Given this list of marker genes Trappc3, Med1, Lhx2, Psph, Rpl27, Zfp882, Spmip8, Gart, Slc6a16, Aamp, Tbc1d8, Apoa1, Acaca, 4933434E20Rik, Hnrnph3, Sgcd, Hsd11b2, Peg12, Sirt1, Elk3, Enoph1, Tmem45a, Purb, Tmem64, Dcp1b, Meis3, 4930505N22Rik, Cobll1, Aven, Uvrag, Mir8102, Nudt6, Sema3a, Trp53inp1 (transformation related protein 53 inducible nuclear protein 1), Plcb4, Idi1, Cdc42ep1, Moap1, Mrm1, Gnpat, Sugct, Msrb1, Cyp39a1, Art3, Lsm1, Zmynd11, Smc2, Csnk1e, Zfp740, Il17ra, Vps13a, Pigo, Gm10517, Gm32950, Gm13375, Zfp11, 4930439D14Rik, Ina, Fhdc1, Arhgap22, Morrbid, Tyro3, Gm27521, Psmb7, Ccdc160, Wnk2, Gm13503, N4bp3, P2ry6, Usp19, Parp9, Zfp703, Baiap2l2, Lin37 (lin-37 DREAM MuvB core complex component), Atxn1l, Naa12, Klc2, B230322F03Rik, Lzts1, Arl1, Fkbp6, Nuak1, Ftx, Ush1g, Agtrap, Adad2, Uchl1, Ptbp3, Coro1a, Mast2, Adam18, Mindy1, Ksr2, Gm4285, Mir6985, Rnf7l, Sgsm1, Selenov, Shox2, Ggta1, Pigh, Mical1, Itpa-ps2, Tsr3, Vti1a, Chmp4b, Il1rl2, Mrps28, Slc2a5, Gas7, Mid1, Tef, 2610206C17Rik, Snrpd3, Ldha, Gdi2, Zfp511, Ccdc141, Dmtf1, Mapt, Ankrd2, Pianp, Plpp4, Cyc1, Mocs2, Pnpla2, Gm20036 (NCBI Gene Id 100504056), Syngr3 (NCBI Gene Id 20974), 4933406P04Rik, Scai, Tdrd3, Psmd4 (proteasome (prosome, macropain) 26S subunit, non-ATPase, 4), Cry1, Crnde, Rpl22l1, Slc41a3, Tle2, Avpi1, Med13l, Rhbdf2, Epha4, C030034I22Rik, Rad54b, Hectd4, Nfkb2, Gmeb1, Rbfox1, Gnal, Rara, Itga3, Gm14010, Zdhhc6, Ssbp3, Obox1, Cnpy2 (NCBI Gene Id 80511), Txndc9, 4632432E15Rik, Gbf1, Trp53bp2, 4731419I09Rik, Mrpl14, Raf1, Elf2, Ppp5c, Foxb1, Trim67, Dpy19l4, Dab2, Hint2, Jakmip1 (janus kinase and microtubule interacting protein 1), Ep300, Crip1, Pcyt1a, Radil, Senp8, Pdlim2, Cbll1, 5330439K02Rik, Eif4a3 (eukaryotic translation initiation factor 4A3), Cul7, Ccnd1, Ark2c, Rassf2, B3galt1, Otop2, Pgm3, Wasf1, Stimate, Pde4dip, Plekha2, Adamtsl1, Pcbp1, Rubcnl (NCBI Gene Id 380917), Zfp872, Dipk2a, Lamtor1, Mcm5, Tex30, Fbxl5, Nrbf2, Zfp36, Ubald1, G430049J08Rik, Prdm14, Itpka, Mir1949, Lrrc42, Mir6420, Hoxa9, Gm16576, Mir22hg, Gm24826, Fam20c, Ddx55, Tent5c (terminal nucleotidyltransferase 5C), Cebpb, Emx2os, Hic1, Fv1, Pet117, Klf13, Cracr2b (NCBI Gene Id 78427), Mob4, Myo1b, Mybl2, Klhdc1, Pmepa1, Mir148b, Gm5544, Tgif2, Sdhaf4, 4931440P22Rik, Rnf166, Ero1a, Emx2, Ap2a2, Cdkn2a, Tbpl1, Wrn, Atxn7l3, Ccdc171, Col14a1, Fkbp8, Imp4, Gm10524, Mest, Tusc1, Sema6c, Ubfd1, Rab4b, Tmem217b, AB041806, Cacna1b, Gm22739, Galnt17, Usp17la, Mroh6, Clip2, Emc9, Cog5, Fam120a, Cyp51, Nyap1, Mex3a, Ncapd2, Mir6904, Gm1848, Large1, Tpt1, Cep170, Lsr, Txndc11, Degs1, Ndufa11, Trmt1, Zfp275 (NCBI Gene Id 71402), Appbp2os, Six4, Usb1, 9030622O22Rik, Sgo1, Pcdhac1, Cdc40, 4833407H14Rik, Lfng, Pmpca, Dmpk, Sppl3, Rit1, Kit, E230001N04Rik, BC048644, Vps54, Arhgap44, Ints3, Gm28818, Pax2, Popdc3, Cmklr1, Rapgef3, Reln, Shld1, Mapkap1, Afg2a, Rps5 (ribosomal protein S5), Tubb2a, 4632427E13Rik, 9430024E24Rik, Evi5l, Mir7216, Slc12a5, Ubap2l, Ptpn9, Eif5, Zdhhc5, Galnt4, Pex14, Klhl22, Wdr13, Asns, Cobl, Espn, Jak2, Col4a2, Mir8090, Ddit4l, Zfp532, Jmjd1c, Tektip1, Fzd1, Calm2, Nacc1 (nucleus accumbens associated 1, BEN and BTB (POZ) domain containing), 5830437K03Rik, Egflam (EGF-like, fibronectin type III and laminin G domains), Mir5103, Usp17lb, Pwwp2a, Sdk2, Acot7, Cct6b, Frg2f1, Rrad, Yipf2 (NCBI Gene Id 74766), Mapk8ip1, Rwdd2a, Lgals3, Myo1c, Ccnd3, Slc29a1, Vps37d, Grm2 (glutamate receptor, metabotropic 2), Slx9, Gm28929, Gm525, Prrc2a, Myrip, Ctu2, Smc1a, Gm19569, Upp2, Zfat, Gins1, Gm15860, Dbp, Coro7, Nxph4 (NCBI Gene Id 68702), Ints10, Klhl14, Trim37, Gm13549, Nefh, Vldlr, Gm13034, Pbld2, D030028A08Rik, Sipa1l3, Pik3r3, Etv1, Obsl1, Gm36823, Wdr87-ps, Ifitm3, Ism2, Ces1b (NCBI Gene Id 382044), Sf3a3, Eaf2, Arhgef2, Cd24a, Bod1, Sema5b, Ccdc184, Gm37233, Cbx7, Trpm7, Brsk2, Kcnc4, Psmb9, 3010003L21Rik, Plpp1, Uchl1os, Dus4l, Wdr1, Zfp830, Dynlrb1, Gabarap, Laptm4a, Sgk1, Inha, Socs2, P3h1, Bcar3, Bmerb1, Vhl, Zswim7, Ada, Cxcr4, Pnkd, Cd82, Det1, Coq2, Hlx, Slc38a2, Tmem222, Bud13, Tefm, Sinhcaf, Nudt19, Vmac, Serping1, Samd4, Fra10ac1 (NCBI Gene Id 70567), H3f3a, Gstp3, Dnase2a, Crip2, Cdv3, Gm12892, Syde2, Nisch, Depdc5, Txnl4a, Trip12, Zmiz2, Erc2, Gnb1, Nhsl1, Cibar2, Phc1, Ntan1, Tmem74, Nfat5, Pkig, Fgfrl1, Paip2b, Ctnna3, Hint3, Gm9967 (NCBI Gene Id 100038751), Gm23435, Mal, Ier5l, Cep250, Smc2os, Bicdl1, Irs2 (insulin receptor substrate 2), Myo10 (NCBI Gene Id 52514), Pnpo, Fbxo32, Rpl19, Gm9710, Son, Gm6288 (predicted gene 6288), Prrx2, Rpap1, Zfp638, Entr1, Eif5b, Skor2, 1600020E01Rik, 5033430I15Rik, Letmd1, Dnmt1, Lama3, Supt5, Prim2, Ift25, D630036H23Rik, Pygb, Ndufa13, Gm12123, Cracd, Esyt2, Nvl (nuclear VCP-like), Ska1, Art5, Ralbp1 (ralA binding protein 1), Slc8a2, Sun2, Foxp1, Glra1, Poc1b, Grk5, Gopc, Lypd4, Isl2, Sf3b3, Slc25a40, Asic3, Notch3, Jmy, Erlin1, Midn, Mir497, Srpra, Oxr1, Tle3, Snx24, 2810004N23Rik, Gm23097, Wwox, Mtss1, Srrm3, Kxd1, Mir195a, Mir497b, Gm4925, Stam2 (signal transducing adaptor molecule (SH3 domain and ITAM motif) 2), Gm17634, Gpbp1l1, Slc25a27, Rps4l, Ankrd10, Acvr1, 4932442E05Rik, Dynlt1b, B230323A14Rik, D930048N14Rik, Fbxl3, Slc25a11, Nek11, Dennd5b, Nubpl, Zbtb4, Pmaip1, Lcmt1, Ifi213, Pcbd2, Aen, Kat14, Cemip2, Rbms1, Ang, Yme1l1, Zfyve1, Gm5841, Fkbp5, Lhx4, Amotl2, Aste1, Gm8810, Katnal2, C2cd3, Hnrnpdl, Snrpe, Tmem60, Elfn1, Swt1 (NCBI Gene Id 66875), Omt2a, Nsf, Gm10655, Rtn4, Prdm15, Tap1, Ripply1, Gm16630, Synrg, Gm15934, Ramp1, Acin1, H2-M10.2, Mapk8, Tfap2a, Syngr1 (NCBI Gene Id 98000), Reep6, Nnat, Mir7238, Prkrip1, Msx3, Camk1, Ypel3, Ssbp1, Fmnl3, Mroh2a, Phf23, Pias2, Zfp553, Gm14042, Stag1, Agap1, Spred2, Yjefn3, Rnase4, Pdp2, Ganab, Pde7a, Tmtc1, Vegfa (NCBI Gene Id 22339), Fblim1, Rbm18, Gm25296, Ppp2r2d, Cadps2, Ccdc136, Agrn, Nob1, Rap1gap, Pltp, Ribc1, Ddx43, Gm5134, Pea15a, Napg, Tardbp, Kctd17, Ndrg4 (N-myc downstream regulated gene 4), Evi5, Cspg4b, Abr, Fam171a2, 4930481A15Rik, Krtap10-4, Gucd1, Jade2, Sirt3, Ripk4, Pals1, AU022252, Gng13, Gm10544, Inava, Rspo1, Psmd13, Opn1sw, Camk2n1, Cd2ap, Lin28a, Cyria, Apbb2, Ptprd, Gm21992, Ccz1, Rasa4, Adck5, Uba2, Usp17ld, Josd1, Tcf24, Top3b, Hey1, Ankrd40, Aff4, Rpl36, Foxj3, Irf5, D630044L22Rik, Psmd11, Cacna2d2 (NCBI Gene Id 56808), Gm23906, Tmem39a, Tubgcp2, Hoxc6, Usp17lc, S1pr3, Lyset, Utp3, Gm2018, Igsf8, Ncor2, Gm7964, Dnmt3b, Fbn2, Srsf6, Lrrc4b, Rbm39, Usp17le, Zdhhc18, Cul5, Mastl, Snx1, Scap, Reep5, Ednrb, Fgd2, Set, Mrpl51, Mir196b, Sptlc1, Xrn2, Large2, Rap1a-ps2, Fnbp1 (formin binding protein 1), Sfrp2, Nsun3, Rps27l, Ipo11, AA386476, Slc20a1, Lyn, Sart1, Grin1, Ing2, Zbtb7a, Ing1, Tanc1, Tmem44, Cpne7 (copine VII), Arhgap21, Lrrc15, Entrep2, Sppl2a, Ift70b, Ears2, Ext1, Mplkip, 4930426D05Rik, Men1, Gps1, Aifm3 (NCBI Gene Id 72168), Purg, Gm26676, Jade1, Rnf167, Zfp629, Crot, Stk11ip, Map2, Setd1b, Pou2f3, Hivep3, Cnih4, Akap1, 1500002C15Rik, BC051665, Nr2e1, Gm11941, Srsf10, Med23, Gm26397, Dmrtb1, Sertad3 (NCBI Gene Id 98671), Gm26524, Lrrc1, R74862, Ctps1, Ralgps2, Prrt2, Plekhg4, Rae1, Car9, Ccdc115, Yju2, Cep170b, Krba1, Bmpr2, Adrm1, Cast, Sidt2, Egf, Zfp764, Gm26839, Pcolce, 4933416M07Rik, Igsf11, here is a description of the gene set: from publication Yevshin I, Sharipov R, Kolmykov S, Kondrakhin Y, Kolpakov F (PMID 30445619) studied in species Mus musculus Mouse Gene Set: ZFP809_TARGET_GENES